Given this list of marker genes Chchd10, Ier3, Bak1, Hip1r, Bcl2l1, Mpv17l, Tmem14a, Slc25a4, Mul1, Bok, Tmem102 (NCBI Gene Id 380705), Acaa2, Siva1, Gclc, Slc25a31 (solute carrier family 25 (mitochondrial carrier; adenine nucleotide translocator), member 31), Slc25a5, Fzd9, Zfp13, Gsk3a, Gsk3b, Slc35f6, Atp5if1, here is a description of the gene set: Mouse Gene Set: GOBP_REGULATION_OF_MITOCHONDRIAL_OUTER_MEMBRANE_PERMEABILIZATION_INVOLVED_IN_APOPTOTIC_SIGNALING_PATHWAY Any process that modulates the frequency, rate or extent of mitochondrial outer membrane permeabilization involved in apoptotic signaling pathway. species: Mus musculus